The following is a description of a gene set: Mouse Gene Set: GOBP_EMBRYONIC_HEMOPOIESIS The stages of blood cell formation that take place within the embryo. studied in species Mus musculus, and this is the list of marker genes: Kmt2a (NCBI Gene Id 214162), Tal1, Kdr, Il3, Tpo, Lmo2, Kdm1a (NCBI Gene Id 99982), Vegfa, Med1, Pbx1, Flt3l, Runx1, Smarca4, Zfpm1, Gata3, Hif1a, Sh2b3, Gata1, Kat6a, Stk3, Ccdc134, Kit, Atf4, Tnrc6c, Stk4, Tgfbr2, Ldb1, Klf1, Gata2, Kitl, Hscb, Thoc5